Given this list of marker genes MOSPD1, ATP7A, FRYL, ZBTB6, MECOM, AHCTF1, SH3RF1, RB1, TAGAP, CSNK2A1, SPAG17, SAMD9, STK24 (serine/threonine kinase 24), TP53TG3B, FAM117B, RNF169, FGG, IGFBP1, PRKCG, ZSWIM2, DNAJB9, ATP1B1, RPS6KB1, HECTD1, TP53TG3, NOP9, VPS26A, FGF12, NOVA1, HIVEP1, SCAMP1, PEG10, PDC, NKAIN2, YIPF6, STMN2, KIAA1549 (NCBI Gene Id 57670), TMEM236, CSTA (cystatin A), HNRNPU, OLIG3, NDRG3, SRR, LRRTM2, GUK1, IRX4, ZPLD1, PREX2, TP53TG3D, APOBEC4 (apolipoprotein B mRNA editing enzyme catalytic polypeptide like 4), CORO2B, COL3A1, ZC3H4, FAM180A, here is a description of the gene set: from publication Chen Y, Wang X (PMID 31504780) Genes predicted to be targets of miRBase v22 microRNA hsa-miR-6514-5p in miRDB v6.0 with MirTarget v4 prediction scores > 80 (high confidence targets). Human Gene Set: MIR6514_5P studied in species Homo sapiens